Given this list of marker genes Ranbp9, Hgf, Hras, Muc20, Grb2, Ranbp10, Shc1 (NCBI Gene Id 20416), here is a description of the gene set: electronically inferred by orthology from the curated human pathway part of: Signaling by MET studied in species Mus musculus Reactome Pathway: MET activates RAS signaling This event has been computationally inferred from an event that has been demonstrated in another species.<p>The inference is based on the homology mapping from PANTHER. Briefly, reactions for which all involved PhysicalEntities (in input, output and catalyst) have a mapped orthologue/paralogue (for complexes at least 75% of components must have a mapping) are inferred to the other species.